The following is a description of a gene set: studied in species Homo sapiens Human Gene Set: GSE37301_CD4_TCELL_VS_GRANULOCYTE_MONOCYTE_PROGENITOR_DN from publication Ramirez K, Chandler KJ, Spaulding C, Zandi S, Sigvardsson M, Graves BJ, Kee BL (PMID 22608498) Expression profiling of Rag2-deficient Ets1++ and Rag2-deficient Ets1-- mature NK cells and WT bone marrow progenitors, WT T cells, and WT Pro B cells Genes down-regulated in CD4 versus granulocyte-monocyte progenitors., and this is the list of marker genes: DCLK2 (doublecortin like kinase 2), IL2, RNF43 (NCBI Gene Id 54894), SEPTIN6, PODNL1, ITGB1, SEMA6D, KCNK5, JARID2, IRF2BP2, PDE4B, KHSRP, LAX1 (lymphocyte transmembrane adaptor 1), GRAMD1B, CDON, CD86, SLC20A1, TMEM67 (transmembrane protein 67), SMAD1, IZUMO1R, CD28, RBBP6, PTGFR, STK39, RXRA, BPIFB1, AAK1, IKBKE, PRKCQ, PAFAH1B3, SESN3, MINK1, RAPGEF1, ENDOD1, TTN, TNFSF11, KYNU, PRMT6, F2R, IVD, VAV3, SMC6, LDHD, MAP4K4, ST8SIA6, NT5E, CCL5, CDC14A, IFT80, SLC38A1, SUSD2, ST6GAL1, PECAM1, RPLP0, ARHGAP26 (Rho GTPase activating protein 26), IKZF1, PLEKHG2, SBK2, DTNBP1, GALNT9, SLC44A2, IL17RB, HIVEP1, TMPRSS11E, LIMK1, BHLHE40, SGPP1, GFRA1, LRIG1, BTLA, AFAP1, PRKCH (protein kinase C eta), ABTB3, PHLPP1, TXK, EPAS1, IL18R1, TLCD1, USP18, TCF7, MBOAT1, TTC8, PENK (proenkephalin), IPCEF1, TRIB1, TADA2A, VCAM1, EIF4E, GPR183, IL2RB, ST8SIA1, GALNT10, AHR, IFNAR2, ABTB2, PLSCR1, RAB11FIP4, MIDN, HMGN2P6, RIMKLA, IL13, BCL2L11, FSD1L, UBASH3A, ATXN2L, ITPR1, MAX, TMEM63C, UTRN, RBM38, MTBP, RNF19A, LTB, RRAS2, PDE11A, PDLIM1 (PDZ and LIM domain 1), ITPKB, FAM78A, TMEM106A, GSAP, TNFSF14, IMMP2L, FOXJ3, RFX5, FCRL1, IL5, VARS1, CD83, IFITM2, SH3GL3 (SH3 domain containing GRB2 like 3, endophilin A3), EVL, ABCG2, MCTP1, ITGAE, RIOK1, TTC3, TSPOAP1, MARCHF3, CBLB, CHST2 (carbohydrate sulfotransferase 2), NOD1, TNIP1, NF1, ZHX2, SAMD3, RFX7, PPFIBP2, PSMB10, VIPR2, ORAI1, VGLL4, ZUP1, VPS37B, ADAMTS6, EHD3, RBL1, IFIH1, CBX4, CCR6, SERP1, SH3KBP1, SLAMF6, RPL18, CYRIA, ARID5A, HIVEP2, NACA, PPP3CC, SEMA4A, PLCB2, RTP4, SLC11A2, TNFSF8, P2RX7, TRAF1, ANKRD55, EIF5A, TIAM1 (TIAM Rac1 associated GEF 1), TIMP2, ASB2